Given this list of marker genes TNFRSF9, CORO1A, ALG12, CD70, POLD1, CBLB, CTPS1, AICDA (NCBI Gene Id 57379), ARHGEF1, MALT1, REL, SHARPIN, CD81, SEC61A1, CD247, TCF3, RIPK1, here is a description of the gene set: Human Gene Set: HP_DECREASED_SPECIFIC_ANTIBODY_RESPONSE_TO_PROTEIN_VACCINE species: Homo sapiens A reduced ability to synthesize postvaccination antibodies against proteins in vaccines, as measured by antibody titer determination following vaccination. Decreased specific antibody response to protein vaccine